Given this list of marker genes KLF12, ZNF746, ELK3, ZC3H8, HOXB13, CDX2, FEZF1, HIVEP1, NFE2L1, E2F8, ZNF589, NFKB1, MYT1L, HOXD9, FOXP4, ETV6, SP2, ZBTB2, SNAI3, THAP11, E2F7, GZF1, THAP1, NFATC2, ZBTB6, ZBTB7A (zinc finger and BTB domain containing 7A), HIC2, PAX6, PROX1, ZBTB45, TCF7, MSX2, ZBTB8A, NKX6-1, NR3C1, BHLHE40, ZNF572, SMAD5, HES2, SMAD3, LRRFIP1, TCF7L2, SATB1, DEAF1, ZNF175, GLIS2, ZNF512B, OTP, MXI1, JPH2, ZBTB25, NR1D2, HSF1, KLF8, PPARG, ESX1, NFE2L3, IKZF5, FOXO1, ZNF536, PRDM16, ZBTB46, JUN, GLIS3, TBX18, GTF2IRD1, ZNF140, ZFP92, FOXP2 (forkhead box P2), FOXR1, ZBTB16, SAMD7, YY1, GFI1, HOXB8, ZBTB34, POU6F1, NKX6-3, INSM2, EN1, IRF3, FOXA2, ZBTB32 (zinc finger and BTB domain containing 32), MYC, DLX4, ZBTB17, FOXO3, TGIF1, FERD3L, ENO1, OVOL2, ZNF91, HEY2, HIC1, TCF3, HES6, POU4F2, ZBTB33, ZNF750 (NCBI Gene Id 79755), HEYL, FOXS1, TFAP2C, ZBTB14, NR2C1, HES5, RARA, NR2E1, PRDM2, ZNF418, ZBTB1, BCL6B, MAX, SOX13, MSC, PROP1, ZBTB21, ZNF354C, VAX2, NR2F6, HSF5, ZBTB18, ZNF219, HES1, PRDM5, TGIF2, ZNF668, ZBTB49, MYPOP, TBX15, ZBED6, ARX, SNAI1, ZBTB5, ZNF224, IRX3, ZNF202, PITX2, FOXK1 (forkhead box K1), SKIL, POU5F1, ASCL3, ETV7, DMBX1, ZNF263, HIF1A, BCL6, NR2F2, SKI, ZNF93, FOXQ1, IRX2, MLXIPL (MLX interacting protein like), SPI1, ZNF85, SALL1, MXD3 (NCBI Gene Id 83463), ZNF239, ETS2, SAMD11, HESX1, ZNF350, MZF1, HELT, ZBTB37, INSM1, ZEB1, E4F1, POU4F1, HHEX, MNX1, PLAGL1, PRRX1, NKX3-2 (NK3 homeobox 2), LEF1, PRDM1, TWIST1, ZNF217, CC2D1A, KLF16, HDGF, NACC2, NFX1, CEBPB, ZBTB12, BCL11A, ZKSCAN3, ZNF134, HINFP, JDP2, SREBF2, MITF, NEUROG3, SP5, IRX1, FOXP1, NANOG, MXD1, NFATC3, NR1D1, ZBTB39, ZBTB4, HEY1, NR6A1, SCRT1, ZBTB20, ZNF692, BATF3, MLX, AEBP1, MSX1, ZNF281, TGIF2LX, SOX6, ASCL1, NFIL3, VSX2, RELA, ZBTB10 (NCBI Gene Id 65986), FEZF2, SP3, ZNF148, CUX2, TGIF2LY, DACH1 (dachshund family transcription factor 1), TBX3, FOXD3, TRPS1, PPARD, ASCL2, E2F6, NFATC4, VAX1, GATA3, ZBTB26, CREB3L1, HOXA2, NR2F1, PATZ1, MNT, HAND1, SOX30, PURA, ATF3, ZBED2, NKX6-2, FOXK2, FOXP3, GSC, ZEB2, ATF7, NACC1, BHLHE41, TFAP2A, TCFL5, PPARA, TP53, ZFHX3, HMX1, OVOL1, IRF8, RORC, ETV3 (NCBI Gene Id 2117), CTCF, BACH1, SCRT2, ZGPAT, ESRRA, TFEC, CC2D1B, TCF21, TBX21, ZBTB7B, TBX2, ZFP90, KCNIP3, ERF, MAFK, PURB, BACH2, SNAI2, CREM, ZNF205, ZNF131, REST (NCBI Gene Id 5978), here is a description of the gene set: studied in species Homo sapiens A DNA-binding transcription factor activity that represses or decreases the transcription of specific gene sets. Human Gene Set: GOMF_DNA_BINDING_TRANSCRIPTION_REPRESSOR_ACTIVITY